The following is a description of a gene set: Mouse Gene Set: GOBP_MYOFIBRIL_ASSEMBLY species: Mus musculus Formation of myofibrils, the repeating units of striated muscle., and this is the list of marker genes: Pdgfrb, Tcap, Actn2, Lmod1, Nrap, Tnnt2, Mef2c, Ldb3, Neb, Prox1, Mybpc3, Neurl2, Actg1, Mef2a, Tpm1, Myoz2, Edn1, Prkar1a, Flnc, Tmod4, Actc1, Myom2, Mybph, Lmod2, Srf, Tmod1, Cfl2, Krt8, Prkd1 (protein kinase D1), Casq1, Tmod2 (NCBI Gene Id 50876), Mfn2, Flii, Klhl41, Capn3, Tmod3, Casq2, Six4, Mylk3, Plec, Ttn, Itgb1, Xirp1, Csrp2, Ep300, Adprhl1, Akap13, Ankrd23 (ankyrin repeat domain 23, NCBI Gene Id 98473), Lmod3 (leiomodin 3 (fetal)), Cavin4, Acta1, Tnnt1, Myh10, Nebl, Cav3, Myom3, Nkx2-5, Myom1, Csrp3, Mybpc1, Wdr1, Krt19, Myl2, Synpo2l, Csrp1, Cflar, Hdac2, Mybpc2, Myh6, Myh11, Pdgfra, Tnnt3, Mypn, Smad4, Bmp10 (bone morphogenetic protein 10), Pgm5, Myoz1, Fhod3, Myl9